The following is a description of a gene set: The dissemination of mature viral particles from a host cell, e.g. by cell lysis or the budding of virus particles from the cell membrane. Human Gene Set: GOBP_VIRAL_RELEASE_FROM_HOST_CELL species: Homo sapiens, and this is the list of marker genes: DDB1, CHMP5, PPID, CAV2, CHMP2A, CHMP6 (NCBI Gene Id 79643), CHMP3, VAPB, TRIM31, TSG101, ZNF502, VAPA, CHMP4C, CHMP7, TRIM62, PPIA, TRIM25, CHMP1A, CHMP2B, RAB7A, VPS4A, ARL8B, VPS4B (vacuolar protein sorting 4 homolog B), CHMP4BP1, CHMP4B, VPS37B, PC, CHMP1B, CHMP4A